The following is a description of a gene set: Catalysis of the reaction: O2 + reduced + testosterone = 6beta,17beta-dihydroxyandrost-4-en-3-one + H+ + H2O + oxidized. Human Gene Set: GOMF_TESTOSTERONE_6_BETA_HYDROXYLASE_ACTIVITY species: Homo sapiens, and this is the list of marker genes: CYP3A4, CYP1B1, CYP3A7, CYP46A1, CYP3A5, CYP3A43